The following is a description of a gene set: Genes predicted to be targets of miRBase v22 microRNA mmu_miR_1982_3p in miRDB v6.0 with MirTarget v4 prediction scores > 80 (high confidence targets). studied in species Mus musculus Mouse Gene Set: MIR_1982_3P from publication Chen Y, Wang X (PMID 31504780), and this is the list of marker genes: Akr1d1, Nr2c2ap, Chtf8, Mafb, Elovl6, Dnm3, Tada1, Itgav, Usp7, Lrrc4c, Lrat, Dcaf11, Def8, Cbx5, Slc6a17, Hgf, Pde4dip, Adamts10 (NCBI Gene Id 224698), Cmah, Wnt6, Zfp322a, Pde6g, Arrb1, Camk1d (NCBI Gene Id 320468), Rufy2, Clec4f (C-type lectin domain family 4, member f), Crnkl1, Appl2, Afap1, Zfhx4, Ap1s2, Osbpl7, Dnajc28, Etfrf1, Ifit2, Bak1, Aak1, Fasl, Ldc1, Notch4, Fbxl5, Grb10, Ankrd55, Capn6